The following is a description of a gene set: studied in species Homo sapiens from publication Papaspyridonos M, Smith A, Burnand KG, Taylor P, Padayachee S, Suckling KE, James CH, Greaves DR, Patel L (PMID 16741146) Human Gene Set: PAPASPYRIDONOS_UNSTABLE_ATEROSCLEROTIC_PLAQUE_UP OBJECTIVE: Comparison of gene expression in stable versus unstable atherosclerotic plaque may be confounded by interpatient variability. The aim of this study was to identify differences in gene expression between stable and unstable segments of plaque obtained from the same patient. METHODS AND RESULTS: Human carotid endarterectomy specimens were segmented and macroscopically classified using a morphological classification system. Two analytical methods, an intraplaque and an interplaque analysis, revealed 170 and 1916 differentially expressed genes, respectively using Affymetrix gene chip analysis. A total of genes were identified from both analyses. The differential expression of genes was also confirmed using quantitative-polymerase chain reaction on a larger panel of samples. Eighteen of these genes have not been associated previously with plaque instability, including the metalloproteinase, ADAMDEC1 (approximately 37-fold), retinoic acid receptor responder-1 (approximately 5-fold), and cysteine protease legumain (approximately 3-fold). Matrix metalloproteinase-9 (MMP-9), cathepsin B, and a novel gene, legumain, a potential activator of MMPs and cathepsins, were also confirmed at the protein level. CONCLUSIONS: The differential expression of genes not previously associated with plaque rupture has been confirmed in stable and unstable regions of the same atherosclerotic plaque. These genes may represent novel targets for the treatment of unstable plaque or useful diagnostic markers of plaque instability. Genes up-regulated in unstable ateroslerotic plaques compared to the stable ones., and this is the list of marker genes: GRN, LAMP1, F11R, ATP2B1, CTSB, RSAD2, LGMN, RPN2, FUCA1, RARRES1, SEL1L3, MS4A4A, SIGLEC15, GM2A, HLA-G, CTSS, PAPSS2, FCGR3A, CD84, MPEG1, SOD2, PLEKHB2, RGCC, ACP5, RBMS1, GLUL, IFI30, CCL18, TDP2, CSF2RB, TRAM1, SLC17A5, SAMSN1, RNASET2, PLA2G7, GALE, DUSP6, BAZ1A (bromodomain adjacent to zinc finger domain 1A), IFIT3, SRGN, NPL, SAT1, CXCL2 (C-X-C motif chemokine ligand 2), RAPGEF1, TRAK2, CD163, NCKAP1L, CREG1, DAB2 (DAB adaptor protein 2), MLEC, IDH1 (isocitrate dehydrogenase (NADP(+)) 1), SGK1, SLC39A8